Given this list of marker genes TAS2R19, PKD2L1, TAS2R7, TAS2R8, TAS2R16, AZGP1 (alpha-2-glycoprotein 1, zinc-binding), TAS2R13, RTP2, TAS2R43, TAS2R50, TAS1R1, TAS1R2, TAS2R3, TAS2R10, RTP4, TAS2R42, CST2, TAS2R60, FFAR4, GNAT2, TAS2R30, RTP5, TAS1R3, PIGR, TAS2R38 (taste 2 receptor member 38), TAS2R9, CST4, RTP1, TAS2R41, TAS2R39, CA6, TAS2R20, PKD1L3, TAS2R46, CST1, PLCB2, LPO, TAS2R31, TAS2R45, TAS2R4, TAS2R1, PIP, TAS2R5, GNAT1, TAS2R40, RTP3, TAS2R14, here is a description of the gene set: The series of events involved in the perception of taste in which a gustatory chemical stimulus is received and converted into a molecular signal. Human Gene Set: GOBP_DETECTION_OF_CHEMICAL_STIMULUS_INVOLVED_IN_SENSORY_PERCEPTION_OF_TASTE studied in species Homo sapiens